The following is a description of a gene set: studied in species Mus musculus Genes predicted to be targets of miRBase v22 microRNA mmu_miR_142b in miRDB v6.0 with MirTarget v4 prediction scores > 80 (high confidence targets). Mouse Gene Set: MIR_142B from publication Chen Y, Wang X (PMID 31504780), and this is the list of marker genes: Fbxo33, Slc5a3, Cfap107, Zfp65, Slc23a2, Clock, Insyn2b, Lrig3, Neo1, Cemip2, Pds5b, Kansl1l, Mfsd14b, Mthfd2l, Rbm34, Tmem65, Casq2, Slc4a4, Tspan14, Stx11, Klhdc10, Ttc7 (tetratricopeptide repeat domain 7), Ubxn2a, Kdm7a, U2af2, Gipc2, Sowahb, Adam24, Ociad1, Flnc, Syndig1, Pakap, Mylip, Clcn3, Dph6, Dbf4, Atxn1, Krr1, Pom121l2, Sh3tc2, Rev1, Capzb, Bmpr1b, Usp37, Rnf157, Adam22, Dhrs13 (dehydrogenase/reductase 13), Senp5, Hnrnpa0 (heterogeneous nuclear ribonucleoprotein A0), Gid4, Il1a, Ubr5, Nfkbiz, Rbfox1, Zfp827, Lix1, Phlda1, Slc4a10, Dnajc3, Tardbp, Rap1a, Tox, Usp25, Vapb, Arhgef9, Ccdc50, Ccser2, Rfpl4b, Ccl17, Snx15, Rnf166, Plscr1, Capn10, Degs1l, Dpp9, Kif1b, Unkl, Ebag9, Pals2, Plk3, Arl15, Shisa6, 1700066M21Rik, Ifngr1, Rbm24, Bbip1, Zcchc4 (zinc finger, CCHC domain containing 4), Lipi, Brsk1, Pramel24, Gjd2, Gdf10, Znrf3, Xiap, B4galt3, Tiparp, Ctdspl2, Atp8b1, Rbpms2, Or7d10, Slit3 (slit guidance ligand 3), Eaf2, Shisa2, Tomm40, Morf4l2, Phip, Aacs, Grn, Slc2a13, Lrrc4c, Dapp1, Mbtps2, Aldh5a1, Slc25a31, Tub, Scg5, Gzmb, Slc25a37, Armcx5, Hoxc8, Cacnb4, Skida1 (SKI/DACH domain containing 1), Rimklb (ribosomal modification protein rimK-like family member B), Pik3cb, C5ar1, Atp8b2, Ppp1cb, Sfpq, Alg10b, Nkx2-2, Kcnab2, Nsd2, Smap1, Isg20l2, Atp8b4, Cpsf6, Fgf5, Sppl2a, Chst5, Pip5k1a, Myoz1, Tfdp1, Rock1, Plekho2, Cpeb2, Ift122, Gad1, Foxa2, Hmx2, Hipk3, Trappc4, Arap2, Tspyl2, Gnai2, Calhm5, Kat6b, Bdp1, Trim33, Zfp933, Cyfip2, Ptprt, Nexmif, Zc3h12c, A530016L24Rik, Fgf12, Trpm3, Plscr2, Prr14l, Kazn, Evi5, Tent5d, Itch, Bmp2, Fgf10, Csnk1g3, Slit2, Rras2, Fbrsl1, Tbc1d15, Rwdd3, Sox17, Zic3, Epn2, Itga9, Dll1, Eya2, Syde2, Atp1b3, Lhx9, Msc, Pramel5, Dmxl1, Ppp4r2, Ocrl, Pias3, L3mbtl3, Sorbs2, Thap4, Cyp7a1, Ccnyl1, Mcmbp, Glra2 (glycine receptor, alpha 2 subunit), Stk26, Gli3 (NCBI Gene Id 14634), Hook3, Slco4a1, Flt3